The following is a description of a gene set: Binding to 2-amino-5-(carbamimidamido)pentanoic acid. studied in species Mus musculus Mouse Gene Set: GOMF_ARGININE_BINDING, and this is the list of marker genes: Slc7a6, Tm4sf5, Nos3, Nos2, Rars1, Castor1, Slc38a9